The following is a description of a gene set: species: Mus musculus Mouse Gene Set: GOBP_REGULATION_OF_CIRCADIAN_SLEEP_WAKE_CYCLE_REM_SLEEP Any process that modulates the frequency, rate or extent of rapid eye movement (REM) sleep., and this is the list of marker genes: Uts2, Uts2r, Chrnb2, Ghrl, Pmch